The following is a description of a gene set: A protein ubiquitination process in which a polymer of ubiquitin, formed by linkages between lysine residues at position 48 of the ubiquitin monomers, is added to a protein. K48-linked ubiquitination targets the substrate protein for degradation. Human Gene Set: GOBP_PROTEIN_K48_LINKED_UBIQUITINATION species: Homo sapiens, and this is the list of marker genes: ANAPC7, ANAPC15, ANAPC1, ANAPC5, ANAPC13, HUWE1, TTC3, DTX3L, UBE2D3, UBE3A (ubiquitin protein ligase E3A), SPSB3, HACE1, TRIM65 (tripartite motif containing 65), KBTBD2, FBXO7, CDC26, MARCHF5, BIRC2, TRIM31, RNF115, RNF126, RNF152, UBE2G2, CUL3, UBE2B, RNF187, RNF5, UBE2D4, DTX4, MYCBP2 (MYC binding protein 2), KBTBD7, KCMF1, KBTBD6, UBE2R2, TRIM38, PPIA, TCF25, TRIM25, RNF216, NEDD4L, UBE3C, UBE2C, PRKN, UBE2D1, TNFAIP3, ANAPC2, RNF146, TRIM45, ZNRF1, UBE2E1, CDC27, TRIM44, CDC16, ZNRF2, ANAPC10, RNF4, SYVN1, CUL1 (cullin 1), UBE2Q2, RNF34, UBE2A, RNF170, CDC23, SKP1, RBX1, FBXO38, RFFL, ANAPC11, UBE2K, ANAPC16, GABARAP, KLHL3 (NCBI Gene Id 26249), TRIM55, AMFR, TOPORS, NT5C2, TRIM6, PELI1, RNF8, ANAPC4, FBXO45, UBE2T, UBE2G1, BTRC, UBE2E2, TRIM21, FBXO9, IFI27, NMI, UBR5, BFAR, ARIH2, SKP2, UBE2E3, RNF6, UBE2D2, ITCH, MARCHF6, CDC34, UBR4, UBE2H